The following is a description of a gene set: Cytokines mediate cell-cell communication in the immune system and represent important therapeutic targets. A myriad of studies have highlighted their central role in immune function, yet we lack a global view of the cellular responses of each immune cell type to each cytokine. To address this gap, the authors created the Immune Dictionary, a compendium of single-cell transcriptomic profiles of more than 17 immune cell types in response to each of 86 cytokines (>1,400 cytokine-cell type combinations) in mouse lymph nodes in vivo. A cytokine-centric view of the dictionary revealed that most cytokines induce highly cell-type-specific responses. For example, the inflammatory cytokine interleukin-1β induces distinct gene programmes in almost every cell type. A cell-type-centric view of the dictionary identified more than 66 cytokine-driven cellular polarization states across immune cell types, including previously uncharacterized states such as an interleukin-18-induced polyfunctional natural killer cell state. Genes negatively differentially expressed in cell type: CD8+ T cell upon treatment with cytokine: Noggin in mouse lymph nodes in vivo. Mouse Gene Set: CUI_T_CELL_CD8_NOGGIN_RESPONSE_DN studied in species Mus musculus from publication Cui A, Huang T, Li S, Ma A, Pérez JL, Sander C, Keskin DB, Wu CJ, Fraenkel E, Hacohen N (PMID 38057668), and this is the list of marker genes: Hspa1b, Btg1, Jun, Klf6, Hspa1a, Junb, Fos, Uba52